Given this list of marker genes UFM1, SRFBP1 (serum response factor binding protein 1), THBS1, ACVR1, FAM20C, CERT1 (ceramide transporter 1), IDO1, CDH6, PIM3, SLC4A2, BRD2, EIF3E, AP2B1, KRCC1, NXF1 (NCBI Gene Id 10482), DERL2, DPYSL2, PDS5A, WDR48 (NCBI Gene Id 57599), OPA1, CALCRL, PSMB7, ZNF503, SH3BP2, PRKRIP1, BHLHE41, OSGIN2, PHF13, NUS1, DLK1, NEAT1, CPEB1, NAMPT, TSC22D1, CFL2 (NCBI Gene Id 1073), TMEM128, KIF9, SPPL2A, PIAS1, YTHDF2, C3, GMFG, EPHA4, ABCA7, GCM1, ITPRID2 (NCBI Gene Id 6744), PLXNA1, ZRANB2, HERC4, TBC1D10B, KLRK1, TPP2, FZD7 (NCBI Gene Id 8324), FEM1B (NCBI Gene Id 23374), GPR88 (NCBI Gene Id 54112), ACSL5, APAF1, PSMC5, FICD, ZFYVE16, TAX1BP1, CCNG2, INO80C, TXN, TNFSF10, SAT1, KCTD10, GOLPH3L, USP47, HLA-B, RGS9, SALL1, HDAC2, HDAC1, OSTF1, NAB2, ATP10A, FAM114A2, MORC3, KCTD14, AMFR, NLGN2, PMP22, FTSJ3, SYNCRIP, IFITM10, SMIM3, PABIR1, ARL1, P2RX7, RBM7, QSOX1, GLIPR2, USP25, LPP (LIM domain containing preferred translocation partner in lipoma), RUSC2, CCL2, LYSMD3, FBXO42, DIAPH2, TAS2R4, KMT2A, MAPK8, DACH1, TRAF3IP2, ABRACL, PDPK1, CARS1, MAP3K7, TRAPPC14, QRICH1, PMEPA1, ZNF260, MED27, OTUD4, HNRNPH3, SPOP, RAB18, COA5, RIMOC1, BLOC1S4, EMC7, CLK3, ARFRP1, CLK4, INPPL1, IFITM3, TBC1D13, ITGAV, GABRG2, MYNN (myoneurin), SNX4, EFR3A (EFR3 homolog A), PAPSS1, KREMEN1, KRTAP19-5, MKKS, C9orf40, GABPA, IER3, BOC, SUSD6 (sushi domain containing 6), GEM, PPP1CB, PLAUR, PPT2, CAVIN4, CCNL2, FAM89A, ACSL4, PRP4K, STAT3, HK2, SLC30A7, PIP5K1A, IGF2BP1, GTPBP1, PPP2CA, TRMT112, ARL14EP, RBL1, TBPL1, GPR85, ST7L, ARHGEF3, SYNPR, JAK2, HECTD1, AZIN1, NFKBIA, HCN2, PIAS4, GSX1 (GS homeobox 1), TDRD7, CCNL1, COL13A1, ATP6V0B, NDRG2, ITPKB, KDM5D, SATB2, PITPNB, CD80, UBE2M, MAD2L1, ZBTB1, BECN1, NUDCD1, RAD17, TBC1D1, CHRD, ATP2A2, TNRC18, COG4, CNOT7, SCNN1G, ENTR1 (endosome associated trafficking regulator 1), SLC6A8, IKBKE, here is a description of the gene set: Genes down-regulated in comparison of dendritic cells (DC) stimulated with Gardiquimod (TLR7 agonist) at 0.5 h versus those stimulated with Gardiquimod (TLR7 agonist) at 8 h. species: Homo sapiens Human Gene Set: GSE17721_0.5H_VS_8H_GARDIQUIMOD_BMDC_DN mouse primary BMDCs were stimulated with tlr ligands and gene expression changes were profiled on Affymetrix arrays from publication Amit I, Garber M, Chevrier N, Leite AP, Donner Y, Eisenhaure T, Guttman M, Grenier JK, Li W, Zuk O, Schubert LA, Birditt B, Shay T, Goren A, Zhang X, Smith Z, Deering R, McDonald RC, Cabili M, Bernstein BE, Rinn JL, Meissner A, Root DE, Hacohen N, Regev A (PMID 19729616)